Given this list of marker genes STMN2, SMIM28, DBH, RET, ATCAY, SCN2A, RIMS3, OLFM1, DRAXIN, PENK, TMEM151B, TUBA1A, TUBB4A, CADM3-AS1 (CADM3 antisense RNA 1), NPY2R, VIP, DOC2A (double C2 domain alpha), SLC10A4, FAM131B (family with sequence similarity 131 member B), HRH3, TTC9B, ENSG00000214803, AKAP6, NUDT10, PHOX2B-AS1, MIR186 (NCBI Gene Id 406962), CCDC171, GNG3, CARTPT (CART prepropeptide), ENSG00000257095, HECW1, CNTNAP2, TMC3, VIRMA-DT, TRIM67, GPRIN1, PCDH15, SLC6A15, SYT9, BCAN-AS1, CHAT, MLLT11, OPRD1, EIF1P6, NPY, WFIKKN2, ARHGDIG, AMER2, NRG1, DPYSL5, TLCD3B (TLC domain containing 3B), APC2, ISLR2, GPR22, UCHL1, ANK2, DLX3, CDH9, TMEM35A, NNAT, MTCL3, MIR137HG, ELAVL3, PHOX2A, PHACTR3, ASTN2, PIRT, DLX6-AS1, KIF5A, SLCO5A1-AS1, KCNIP4, EML5, RAB6B, PTPRR, DLL3, ELAVL4, TUBB2A, TUBB3, CNGB1, ZNF843, HMX2, LHFPL3 (LHFPL tetraspan subfamily member 3), DLX5, MIAT, ATP1A3, LINC02691, CRABP1 (cellular retinoic acid binding protein 1), DNER, CACNA1E, NRSN1, STMN4, TUBB2B, SEMA3E, CTXN2, GAP43, KIAA0408, DSCAM, MYH15, MED12L (mediator complex subunit 12L), SRRM4, HCN1, KCNK15-AS1, NBAT1, FSD1, GULOP, TMEM59L, MKX, INA (NCBI Gene Id 9118), SULT4A1, RIMS4, PKP1, SLCO6A1, RPL21P2, PLPPR3, PCBP3, RIMS1, GCNT2P1, GAL, SLC18A3, CHRNA7, PCDH10, MAP1B, ABCA12, CLVS2, NOS1, UNC5C, FGF13, OPRM1, RGMB, MDP1, BUB3, PUS1-AS1, SYNGR3, NRG1-IT1, CHD5 (NCBI Gene Id 26139), ENSG00000250781, FAM163A, OLFM3, TLX2, EPO, LINC03047, LINC02986, LINC01587, ENO2, LIX1, JAKMIP1, PRPH, GRIN1, RPL24P4, VAT1L (vesicle amine transport 1 like), PCDHB2, SYT1, DPYSL3, JPH3, ATP2B3, DLX6, GRP, TMC3-AS1, TROAP-AS1, CHRNA3, NEFH, TTBK1, NSG2, CNR1, SPIN2B, FTH1P16, here is a description of the gene set: The gene expression program underlying the specification of human cell types is of fundamental interest. The study authors generated human cell atlases of gene expression and chromatin accessibility in fetal tissues. For gene expression, the study authors applied three-level combinatorial indexing to >110 samples representing 15 organs, ultimately profiling ~4 million single cells. The study authors leveraged the literature and other atlases to identify and annotate hundreds of cell types and subtypes, both within and across tissues. Our analyses focused on organ-specific specializations of broadly distributed cell types (such as blood, endothelial, and epithelial), sites of fetal erythropoiesis (which notably included the adrenal gland), and integration with mouse developmental atlases (such as conserved specification of blood cells). These data represent a rich resource for the exploration of in vivo human gene expression in diverse tissues and cell types. Human Gene Set: DESCARTES_FETAL_PANCREAS_ENS_NEURONS Marker genes curated from the annotated cluster as represented in the Descartes Human Gene Expression During Development database. species: Homo sapiens from publication Cao J, O'Day DR, Pliner HA, Kingsley PD, Deng M, Daza RM, Zager MA, Aldinger KA, Blecher-Gonen R, Zhang F, Spielmann M, Palis J, Doherty D, Steemers FJ, Glass IA, Trapnell C, Shendure J (PMID 33184181)